Given this list of marker genes CPNE8, PTPN5, SENP6, DCLK1, RNF138, NFYC, CCDC85C, AGO4, RMND5A, MEGF9, ZNF516, PRKAB1, SNX25, WNT16 (Wnt family member 16), ZBTB7A, SLC1A5, SSX2IP, SERP1, NKAPD1, ZNF385D, HMGN3, SYNDIG1, GIT2, MED21, MBTPS2, FMNL2, CRKL, STK11, AHCYL1, ATG14, OSBP2, ESRRG, VWA5B2, MAPK10, TIGD1 (tigger transposable element derived 1), MRPS5, NOX4, RGS6, GALNT1, NF1, INPP5A (inositol polyphosphate-5-phosphatase A), FGF9, JADE1, PAXBP1, NRG1, NAT8L, ANKRD28, PTN, ZNF770, SPATA16, ABHD13, MLC1, DIRAS2, STRBP, TRIM33, LBH (LBH regulator of WNT signaling pathway), NFASC, KLF15 (KLF transcription factor 15), CDC37L1, KIAA1671, IMPA2, SCRT2, ATP11B (NCBI Gene Id 348830), DDX3X, CISD1, CCDC126, RANBP9, GPD2, PARP4, PLK2, DENND1B, AIDA, PRDM1, C2CD2, DEXI, MTDH, MED27, SIRT6, DOCK8, FAM98A, COCH, STAC, CPD, LINGO2, ARK2N, NCOA2, NCK1, ELOVL2, HLTF, SLC5A7, DR1, ERBIN, STRN, RGS7BP, GLIS2 (NCBI Gene Id 84662), OXSR1, KANK4, DESI1, FGL2, DAG1, SPRY3, KCNB2, RREB1, MSRB3, RNF150, FAT3 (FAT atypical cadherin 3), SOX6, PLCB1, HOXC4, JAKMIP2, ZC3H3, SHROOM2, CXCL14, OXR1, RDX, MED11, TMEM33, TDRD7, PGP, ABHD2, STK38, CST11, IFT20, EPC2, DMRT3, OTUD4, SLC43A2, COL11A1, SEZ6L2, OSGEP, ADAMTS5, MAN2A1, ARSD, PDCD6, HTN3, CUL3, RICTOR, WBP1L, SYNCRIP, METTL9, KDM1A, VASH2, DUSP5, CADPS, GPAM, BTAF1, MSI2, ZBTB7B, VAX1, NXT2, SH3TC1, KLF12, NRG3, ST3GAL3, SRC, FXR1, CYYR1, ZBTB21, GORASP2, MITF, AMD1, RIC8B (RIC8 guanine nucleotide exchange factor B), MBNL2, GBP3, YBX3, RETREG3, RBM41, ZNF621, ENSG00000275993, NREP, PHTF2, SASH3, RCOR2, SEPTIN3, ATP2B2, RAVER2, AJUBA, NIPBL (NCBI Gene Id 25836), CXXC4, TPCN1, POLR2C, HIC1, FNDC5, ITPR3 (NCBI Gene Id 3710), NECAB3, LIMCH1, PTPN2, RNGTT, SIPA1L2, HYCC2, ZFYVE16, SCN8A, CHORDC1, PXN, UNC79, CACNA1I, EDIL3, ZNF736, B3GALT2, TCF3, FAM168A, TSN, CXADR, MPC1, NUCKS1, ARID4B, CTNNA3, GRAMD2B, UBE2K, GRM7, PALM2AKAP2 (PALM2 and AKAP2 fusion), STK40, UBN2, NEFH, DUSP4, SLC35A4, LMTK2, CTSF, SNRK, CYB5R4, MICU1, CALCOCO1, CACNA1H, BBX, ZDHHC5, SOAT2, YTHDC1, ZNF449, CCNG2 (NCBI Gene Id 901), CLEC16A, RELL1, FGF11, C11orf87, ZNF224, PIAS2, CNEP1R1, AGGF1, TAF7L, ACSL6, RAPGEF5, TRPC5OS, CACNA1G, SLC4A7, RAPH1, LMBR1L (NCBI Gene Id 55716), TLCD4, STK38L, LUZP2, GXYLT1, CTDSP2, DMRT2, USP30, TMEM218, HNRNPDL, CHST10, FOXC1, GPCPD1, SLC7A9, ZNF217, EMCN, RAB9A (NCBI Gene Id 9367), NFIB, PTGFRN, HLF, WWP2, SLC6A9, PRKD3, MAP3K20, PAQR3, AQP8, DFFB, MARCHF7, IFT56, NABP1, ZNF710 (zinc finger protein 710), NDST1, RSBN1 (NCBI Gene Id 54665), ZNF804A (zinc finger protein 804A), DIPK2A, PRKAA1 (protein kinase AMP-activated catalytic subunit alpha 1), ALPG, NFATC2, AP3S1, QKI, ZNF555, ATP10A, SSR3, MBOAT2, KCNAB3, NBEA, TMPO, GLCE, SLC6A8, TBC1D19, ZNF143, SBSPON, SGCG, ABHD6, UBE2G1, KDM5B (NCBI Gene Id 10765), ASPH, KLHL28, PRADC1, QSER1, TRIM45, GOLGA7, MIER3, NETO1, BCOR, HTR2C, TBC1D1, ZNF343, EOGT, UGCG, LURAP1L, MAML1, BAZ1A, JMY, CD2AP, EVX1, SLC17A6 (solute carrier family 17 member 6), PDLIM3, PLXDC2, EPHA5, PITPNA, ZFP36L2, WNT7A, DAAM1, ZNF326, KCNMB2, CTTNBP2NL, ICA1L, FXYD6, GRIA4, STYX, SCRT1, CEP128, PRR16, SWT1, DCDC2, MPP1, TBCE, MXD1, FTHL17, NRG2, CAPN2 (calpain 2), SMCP, SUSD3, ABHD17A, GIPC2, XPO4, GRAMD4, PIK3R3, AP1S3, NPC1, KDM4A, OTUD7B, TMLHE, PYURF, SSBP2, GPR137B, HERPUD2, ARHGAP5, CILK1, DUSP10, LZTS3, C6orf47, CDH12, KMT2A, SYT1, GUCY1A2, NATD1, MYO1D, PRKAR2B, GABRA1, CTTNBP2, ARHGAP44, DIP2C, PXDNL, DLGAP1, SBNO1, COL5A1, ATXN1L (ataxin 1 like), SOX11, ABI3BP, CALN1, SKI, TTC28 (NCBI Gene Id 23331), NCOA3, GRK6, RRM2B, ING2, FAM117B, SLC35A1, C17orf58, CSNK1G3, TMEM229B, FHIP2B, ENHO, RBPJ, NRP1, STATH, ARHGEF18, ANKRD44, DTX2, E2F6, BRAF, SLMAP, LBX1, SLC35E2B, CHD9, SIK1, ACAP2, PTPN4, USP36, SLC36A4, KCND2, TMSB15B, ACSBG2, DCUN1D1 (NCBI Gene Id 54165), EIF3J, E2F7, RBM27, RTKN2, UBE3C, FRMD6, ZCCHC2, TFAP2A, KDELR3, PIGY, TENT4A, CNTN3, ARHGAP24, SLC30A4, SLC12A2, EFR3A, LONRF3, ADCY2, MYBPC3, UBLCP1, CABLES2, GRM5, AGPAT3, SLC8A1, HTN1, MAP3K14, NEUROD1, PCGF5, RNF213, LGI3 (leucine rich repeat LGI family member 3), ST13, ANKRD12 (ankyrin repeat domain 12), PDE4A, SLC25A5, RHOBTB1, TMEM80, SLC16A9, CASTOR2, GDPD1, ABHD18, MARCHF8, FNIP1 (folliculin interacting protein 1), CSDC2, RRAGD, TSC22D2, AHCYL2, SGPL1, RAP2C, SYF2, TRAF3, ADO (NCBI Gene Id 84890), RNF4, TCF12, FAM78A, EFCAB14, STT3B, RWDD4, KLHL21, NSG1, NCKAP5, BCORL1, EPHA7 (NCBI Gene Id 2045), PIP4P2, GTF2A1, LCP2, SLC46A3, PPARGC1A, ITPRIP, RNLS, ZMYM2, ARHGAP42, CA7, GJC1, EIF2S3, EGR2, RORA, ESRRA, SGO1, YTHDF3, KIT, RIC1, ZC3H6, PPP4R2, TCF4, SLC12A6 (solute carrier family 12 member 6), LEMD3, MSI1, CADM2, FURIN, NCAPH2, GFPT1, FZD3, ATF7IP2, APPL2, SPATA13, DTNA, TSNAX, PNKD, KHDC4, PHF20, PPP1CB, B4GALT5, GRIP1, PLEKHO2, FKBP4, COL19A1, NKAIN1, SS18, LIN7A, NEUROD4, TJP2, here is a description of the gene set: Genes predicted to be targets of miRBase v22 microRNA hsa-miR-137-3p in miRDB v6.0 with MirTarget v4 prediction scores > 80 (high confidence targets). from publication Chen Y, Wang X (PMID 31504780) Human Gene Set: MIR137_3P studied in species Homo sapiens